Given this list of marker genes SLC2A9, PAX2, VPS50, KARS1, DKC1, WDR19, SLC22A12, here is a description of the gene set: Mild proteinuria Mildly increased levels of protein in the urine (150-500 mg per day in adults). species: Homo sapiens Human Gene Set: HP_MILD_PROTEINURIA